The following is a description of a gene set: species: Homo sapiens CS/DS degradation Human Gene Set: REACTOME_CS_DS_DEGRADATION, and this is the list of marker genes: VCAN, NCAN, BCAN, BGN, HEXB, ARSB, CSPG4, IDUA, CSPG5, HEXA, DCN, HYAL3, IDS, HYAL1